Given this list of marker genes TAF6L, TAF3, TAF5, TBP, TAF11L6, TAF11L8, TAF9B, TAF11L2, TAF1, GTF2H4, GTF2B, GTF2H3, TAF11L10, GTF2E1, TAF2, TAF8, TAF11L14, TAF12, TAF7L, TAF11, TAF1L, TAF4B, PAAF1, GTF2A1, GTF2H2, TAF13, GTF2F1 (NCBI Gene Id 2962), ERCC2, TAF11L12, GTF2A2, TAF4 (NCBI Gene Id 6874), TAF9, GTF2H5, TAF11L13, TAF11L4, TAF11L3, TAF5L, TAF6, TAF11L7, TAF10, TAF11L9, TCEA1, ERCC3, TAF11L11, GTF2E2, TAF7, here is a description of the gene set: Human Gene Set: GOCC_TRANSCRIPTION_FACTOR_TFIID_COMPLEX species: Homo sapiens A complex composed of TATA binding protein (TBP) and TBP associated factors (TAFs); the total mass is typically about 800 kDa. Most of the TAFs are conserved across species. In TATA-containing promoters for RNA polymerase II (Pol II), TFIID is believed to recognize at least two distinct elements, the TATA element and a downstream promoter element. TFIID is also involved in recognition of TATA-less Pol II promoters. Binding of TFIID to DNA is necessary but not sufficient for transcription initiation from most RNA polymerase II promoters.